The following is a description of a gene set: Human Gene Set: HP_BILATERAL_COXA_VALGA studied in species Homo sapiens Bilateral coxa valga The presence of bilateral coxa valga., and this is the list of marker genes: UBE3C, MAN2B1, LMX1B, TGFB3, COL9A1, UFC1, COG8, ERCC6, COL9A2, PDE4D, CCDC47, STXBP1, COL9A3